Given this list of marker genes RPS5, RNF130, UXT, BTG1, PLSCR3, KLF2, PDXK, ASAH1, S1PR1, ASAP3, CMC4, FGF9, CD55, DZANK1, APOC4, PBXIP1, FAM171A1, ATP4A, DHRS9, GSTK1, FAIM2, BST2, PLCB2, HLA-G, PIK3CD, ZNF331, FBL, INPP4B, PCDH11X, BIN1, TIMP1 (NCBI Gene Id 7076), EMD, GID8, PGM5, HEG1, IMPDH1, SH2D3A, GALNT11, IL4R, TCF20, APOL1, CYLD, IL6ST, MRNIP, GGT1, RPLP2, RPL26, HLA-E, FLT3LG (fms related receptor tyrosine kinase 3 ligand), WDR4, MGAT4B, DUSP13B (NCBI Gene Id 51207), SLC15A3, CPZ, IFITM2, MDN1, CRY2, RPS29, WDR46, CREG1, PEX16 (NCBI Gene Id 9409), C3orf18, LITAF, MVP, SORL1, CYP3A4, LPCAT3, TLR6 (toll like receptor 6), SCARB2, NR3C2, MINDY1, CIDEB, FOXJ2, IDS, ARHGAP45, RPL10P17, SERP1, TBC1D4 (TBC1 domain family member 4), CXCL12, GIMAP6, CAMSAP2, CHIT1, CRAT, HHIPL2, DENND4B, BTN3A3, NBPF10, GRB10, B4GALT4, MEGF6 (NCBI Gene Id 1953), CYTH1, SH3YL1, CRTC3, WWP1, RPS19, TTC13, CSNK1E, FAU, RPS8, STX3, ANKH, CDC14B, PDE4B, CCND2, DGCR2, ALDH1L1 (NCBI Gene Id 10840), DSCAM (NCBI Gene Id 1826), ST13, CYTIP, APOL2, TNFRSF14, RPL10L, EEF1D, WWC3, RPL36A, RPS13, JADE2, HABP4, DTX4, HTR7, TRAF3, EXOSC5, RPL13, SLC6A8, RAB29, ZMYND11, MIP (major intrinsic protein of lens fiber), RPS27, CD44, TET3, NCK2, EHHADH, SQSTM1, GSTT1, HSPA8, TMEM204, TMBIM1, ALDH3A2, RPS18, PIM1, TNIP1, STX16, SRPRB, CSDE1, APOBR, BCL2, SCN5A, RPS17P5, SORCS3, PCYOX1L, FGF6, UBA7, TNFRSF25, RPL36AL, ARL6IP5, HLCS, RPS6 (ribosomal protein S6), AP3M2, PPIP5K1, EHD1, PDE4DIP, ADARB1, RPL32, FUCA1, SULT1B1, CIB1, RPL27A, FBXO46, NET1, IFNGR2, NENF, ADI1, S1PR4, RPS7, ITGA6, ADIPOQ, ABLIM1, COL6A1, RBL2, DENND2D, FN3KRP, ULK2, RPL12, LY75, TMPRSS6, RPL10A, ITGB2, TCN2, RRAS, CD53, NLRP1, PFDN5, PXN, SOCS2, NOTCH2NLA, SLC50A1, CSF3, here is a description of the gene set: Subpopulations of human fetal thymocyte and circulating naïve T cells were obtained through FACS sorting, including CD3-CD4+CD8- intrathymic T progenitor cells (ITTP), CD3intCD4+CD8+ \double positive\ thymocytes (DP), CD3highCD4+CD8- \single positive\ thymocytes (SP4), CD3+CD4+CD8-CD45RA+CD62L+ naive T cells from cord blood (CB4+), and CD3+CD4+CD8-CD45RA+CD62L+ naive T cells from adult blood (AB4+). studied in species Homo sapiens from publication Lee MS, Hanspers K, Barker CS, Korn AP, McCune JM (PMID 15210650) Human Gene Set: GSE1460_DP_THYMOCYTE_VS_NAIVE_CD4_TCELL_ADULT_BLOOD_DN Genes down-regulated in comparison of CD4 CD8 thymocytes versus naive CD4 T cells from adult blood.